The following is a description of a gene set: A hole (perforation) in the wall of the colon. Human Gene Set: HP_COLON_PERFORATION studied in species Homo sapiens Colon perforation, and this is the list of marker genes: SEMA3D, RET, ERBB3, ABCD1, GATA6, ATP7A, ERBB2, NRTN, EDNRB, SEMA3C, ECE1, EDN3, SREBF1, GDNF, SMO